The following is a description of a gene set: Transferrin endocytosis and recycling Mouse Gene Set: REACTOME_TRANSFERRIN_ENDOCYTOSIS_AND_RECYCLING species: Mus musculus, and this is the list of marker genes: Atp6v0d1, Atp6v0a1, Atp6v0e, Atp6v0c (NCBI Gene Id 11984), Atp6v1b2, Atp6v1g2, Atp6ap1, Atp6v1c2, Steap4, Atp6v1e1, Atp6v1g3, Tcirg1, Atp6v1a, Tfr2, Atp6v0e2 (ATPase, H+ transporting, lysosomal V0 subunit E2), Atp6v1b1, Atp6v1h, Steap3, Mcoln1, Atp6v0a2, Atp6v1d, Atp6v1f (ATPase, H+ transporting, lysosomal V1 subunit F), Hfe, Atp6v0a4, Atp6v0b, Atp6v1e2, Atp6v0d2, Atp6v1g1, Trf (NCBI Gene Id 22041), Atp6v1c1, Tfrc